Given this list of marker genes CDON (NCBI Gene Id 50937), DHH, HHIP, IHH, SHH, GAS1, BOC, PTCH1, here is a description of the gene set: Reactome Pathway: Ligand-receptor interactions species: Homo sapiens part of: Hedgehog 'on' state Repression of Hh signaling in the absence of ligand depends on the transmembrane receptor protein Patched (PTCH), which inhibits Smoothened (SMO) activity by an unknown mechanism. This promotes the proteolytic processing and/or degradation of the GLI family of transcription factors and maintains the pathway in a transcriptionally repressed state. In the absence of ligand, PTCH is localized in the cilium, while SMO is largely concentrated in intracellular compartments. Upon binding of Hh to the PTCH receptor, PTCH is endocytosed, relieving SMO inhibition and allowing it to accumulate in the primary cilium. In the cilium, SMO is activated by an unknown mechanism, allowing the full length transcriptional activator forms of the GLI proteins to accumulate and translocate to the nucleus, where they bind to the promoters of Hh-responsive genes. <br>In addition to PTCH, three additional membrane proteins have been shown to bind Hh and to be required for Hh-dependent signaling in vertebrates: CDON (CAM-related/downregulated by oncogenes), BOC (brother of CDO) and GAS1 (growth arrest specific 1). CDON and BOC, homologues of Drosophila Ihog and Boi respectively, are evolutionarily conserved transmembrane glycoproteins that have been shown to bind both to Hh ligand and to the canonical receptor PTCH to promote Hh signaling. Despite the evolutionary conservation, the mode of ligand binding by CDON/Ihog and BOC/Boi is distinct in vertebrates and invertebrates. High affinity ligand-binding by CDON and BOC requires Ca2+, while invertebrate ligand-binding is heparin-dependent. GAS1 is a vertebrate-specific GPI-anchored protein that similarly binds both to Hh ligand and to the PTCH receptor to promote Hh signaling. CDON, BOC and GAS1 have partially overlapping but not totally redundant roles, and knock-out of all three is required to abrogate Hh signaling in mice.